The following is a description of a gene set: Human Gene Set: DESCARTES_FETAL_LUNG_BRONCHIOLAR_AND_ALVEOLAR_EPITHELIAL_CELLS from publication Cao J, O'Day DR, Pliner HA, Kingsley PD, Deng M, Daza RM, Zager MA, Aldinger KA, Blecher-Gonen R, Zhang F, Spielmann M, Palis J, Doherty D, Steemers FJ, Glass IA, Trapnell C, Shendure J (PMID 33184181) studied in species Homo sapiens The gene expression program underlying the specification of human cell types is of fundamental interest. The study authors generated human cell atlases of gene expression and chromatin accessibility in fetal tissues. For gene expression, the study authors applied three-level combinatorial indexing to >110 samples representing 15 organs, ultimately profiling ~4 million single cells. The study authors leveraged the literature and other atlases to identify and annotate hundreds of cell types and subtypes, both within and across tissues. Our analyses focused on organ-specific specializations of broadly distributed cell types (such as blood, endothelial, and epithelial), sites of fetal erythropoiesis (which notably included the adrenal gland), and integration with mouse developmental atlases (such as conserved specification of blood cells). These data represent a rich resource for the exploration of in vivo human gene expression in diverse tissues and cell types. Marker genes curated from the annotated cluster as represented in the Descartes Human Gene Expression During Development database., and this is the list of marker genes: CLDN18, SFTPB, CRLF1 (NCBI Gene Id 9244), PTCSC3, SLC22A3, HAS3, PALM3 (NCBI Gene Id 342979), KCNJ5, CPM, RNF220, AGER, LINC01426, LMO7DN, ENSG00000250978, PLCZ1, CLDN6, RPS29P11, FGF20, CLDN2, DMBT1, ROS1, CDH16, ETV5, PPP1R3A, EDN3, CCDC198, PKHD1, LINC03007, SP5, SLC34A3, LAMP3, SLC34A2, UGT2B7, ADCY8, RBBP8NL, GGT2P, LINC02307, KCNJ15, DACT2, FREM3, ATP11A (ATPase phospholipid transporting 11A), PIK3C2G, C10orf90 (NCBI Gene Id 118611), ENSG00000256615, FGFR2, SFTA3, IRX6, ENSG00000254951, FAM41C, GPX6, SPMIP8 (sperm microtubule inner protein 8), ODAM, SLC19A3, SFTPC, ENSG00000214708, PGC, LINC01331, H1-9P, IL12A-AS1, LHFPL3-AS1, MAP3K21, SLC10A2, KIF12, ITGB6, SUSD2, TPD52L1, SMIM43, ACOXL